The following is a description of a gene set: Any process that establishes and transmits the specification of sexual status of an individual organism. studied in species Homo sapiens Human Gene Set: GOBP_SEX_DETERMINATION, and this is the list of marker genes: INSRR, DHH, SIX4, MAP3K4, WT1, DMRT1, AMH, GNRH1 (NCBI Gene Id 2796), CITED2, NR5A1, WNT4, FOXL2, INSR, NR0B1, AR, SRY, SOX9, TCF21, SOX3, FGF9, PTGDR, SRD5A1